Given this list of marker genes SERPINB1, SESN2, WARS1, XCL2, TRIM22, VNN1, IER3, CSF3, PMAIP1, ADORA2A, EML2, MT2A, UBE2L6, OAS3, FEZ1, RIPK2, SLC22A1, AARS1, PHLDA2, CKB, TNF, IRF1, PYCR1, DUSP5, VPREB3, NEU4, CD38, MMP10, MAP3K8, MARS1, SLC7A7, RGS3, OSM, LTA, IRF4, CXCL3, SOD2, APOL3, PSMB9, CCL4, IDO1, GNG8, NFKB1, ISG15, CCL22, CCL3, PTX3, PIM1, MMP14, TNFSF4 (TNF superfamily member 4), LIF, GBP1, F3, TRIB3, RUNX3, ABTB2, CXCL8, GBP4, PHGDH, PSME2, SLC7A5, FERMT2, NME2, HECW2, CXCL2, IFIH1, PIM2, G0S2, CSF2, IL1A, IL6, ACOT7, CCL20, IFI44L, TRAF4, TFPI2, ADA, EDN1, BCL2A1, CCL1, SERPINA1, SERPINB7, MX1, IL36G, NAMPT (NCBI Gene Id 10135), GADD45B, SERPINB2, RNF144B, IRF9, MMP1, PARP9, CXCL10, C2CD4B, MTHFD1L, PSAT1 (NCBI Gene Id 29968), LAMP3, BATF, EPSTI1, D2HGDH, GBP2, DDIT4, TNFAIP6, VNN3P (NCBI Gene Id 55350), EBI3, PTGS2, IL12B, APOL1, AKR1C2, CHAC1, CXCL1, CD93, PLAAT4, AQP9, CXCR5 (C-X-C motif chemokine receptor 5), NFKBIZ, GBP5, CITED4, IFIT3, SOCS1, IL1B, ASPHD2, ASNS, STAT1, BATF3, ZMIZ2, HDGFL3, here is a description of the gene set: BACKGROUND: Novel tuberculosis (TB) vaccines recently tested in humans have been designed to boost immunity induced by the current vaccine, Mycobacterium bovis Bacille Calmette-Guerin (BCG). Because BCG vaccination is used extensively in infants, this population group is likely to be the first in which efficacy trials of new vaccines will be conducted. However, our understanding of the complexity of immunity to BCG in infants is inadequate, making interpretation of vaccine-induced immune responses difficult. METHODS: To better understand BCG-induced immunity, we performed gene expression profiling in five 10-week old infants routinely vaccinated with BCG at birth. RNA was extracted from 12 hour BCG-stimulated or purified protein derivative of tuberculin (PPD)-stimulated PBMC, isolated from neonatal blood collected 10 weeks after vaccination. RNA was hybridised to the Sentrix(R) HumanRef-8 Expression BeadChip (Illumina) to measure expression of > genes. RESULTS: We found that ex vivo stimulation of PBMC with PPD and BCG induced largely similar gene expression profiles, except that BCG induced greater macrophage activation. The peroxisome proliferator-activated receptor (PPAR) signaling pathway, including PPAR-gamma, involved in activation of the alternative, anti-inflammatory macrophage response was down-regulated following stimulation with both antigens. In contrast, up-regulation of genes associated with the classic, pro-inflammatory macrophage response was noted. Further analysis revealed a decrease in the expression of cell adhesion molecules (CAMs), including integrin alpha M (ITGAM), which is known to be important for entry of mycobacteria into the macrophage. Interestingly, more leukocyte genes were down-regulated than up-regulated. CONCLUSION: Our results suggest that a combination of suppressed and up-regulated genes may be key in determining development of protective immunity to TB induced by vaccination with BCG. from publication Fletcher HA, Keyser A, Bowmaker M, Sayles PC, Kaplan G, Hussey G, Hill AV, Hanekom WA (PMID 19239680) Genes up-regulated in peripheral blood mononuclear cell stimulated vs unstimulated in infants (10w) after exposure to BCG (Danish strain BCG Statens Serum Institut, Denmark), time point 10W. Comment: PBMCs drawn at 10 weeks following immunization at birth studied in species Homo sapiens Human Gene Set: FLETCHER_PBMC_BCG_10W_INFANT_BCG_STIMULATED_VS_UNSTIMULATED_10W_UP